Given this list of marker genes GNAS, SAR1A, RIT2, GNAQ, RAB39A, GNAL, RAC1, RAB9B, NRAS, RAP1A, RIT1, ARF6, RAP2C, GNAI1, RAB1C, RAB1B, RAB35, RALA, RAB2A, RAB27A (RAB27A, member RAS oncogene family), RAB5C, RAB14, GNAO1, RAN, RAB30, RAB5B, RAP2B, RERG, HRAS, RAB11B, SAR1B, RALB, RAB37, RAP2A, KRAS, RAB24, CDC42, RERGL, RAB10, RAB27B, RAB9A, RASL11B, RAB33B, RASL10A, ARL8B, IRGM, RAB5A, RAB7A, RAB1A, RAB11A, MRAS, ERAS, RASL12, RAC3, GNA13, RAB4B, RAB15, GBP1, RASL11A (NCBI Gene Id 387496), RAB28, RASL10B, GNA12, RAP1B, RAB25, RHOA, GNA11, RAB4A, here is a description of the gene set: species: Homo sapiens Human Gene Set: GOMF_G_PROTEIN_ACTIVITY A molecular function regulator that cycles between active GTP-bound and inactive GDP-bound states. In its active state, binds to a variety of effector proteins to regulate cellular processes. Intrinsic GTPase activity returns the G protein to its GDP-bound state. The return to the GDP-bound state can be accelerated by the action of a GTPase-activating protein (GAP).